The following is a description of a gene set: The intramolecular conversion of uridine to pseudouridine in an rRNA molecule. Human Gene Set: GOBP_RRNA_PSEUDOURIDINE_SYNTHESIS studied in species Homo sapiens, and this is the list of marker genes: GAR1, NHP2, RPUSD2, NOP10, DKC1, RPUSD4, RPUSD1, TSR3, NAF1